The following is a description of a gene set: part of: G1 Phase electronically inferred by orthology from the curated human pathway species: Mus musculus This event has been computationally inferred from an event that has been demonstrated in another species.<p>The inference is based on the homology mapping from PANTHER. Briefly, reactions for which all involved PhysicalEntities (in input, output and catalyst) have a mapped orthologue/paralogue (for complexes at least 75% of components must have a mapping) are inferred to the other species. Reactome Pathway: Cyclin D associated events in G1, and this is the list of marker genes: Ccnh, Ubb, Cdkn1b, Rps27a, Cdkn1a, Tfdp1, E2f1, Rb1 (RB transcriptional corepressor 1), Ccne2, Ccne1, Cdkn2b, E2f3, Ccnd1, Ppp2r1b, Cdkn1c, Cdk4, Ppp2r2a, Cul1, Rbl2